Given this list of marker genes WDR36, NUP107-DT, CUL3, RNU6-1309P, RAVER2, ISL2, RUNX1, KHNYN, AP1S3, WEE2-AS1, TBC1D22A-DT, TMEM167B, CCDC77, UCHL5, HBP1, TRAF3IP3, GPX3, TIAM1, SMARCD2, HPRT1, ABCC8, ZNF354B, MTCO3P12, IFTAP, LINC00265, HNRNPMP2, MTA3, NDUFAF1, ADAT2, GTF2F1, INTS9, PAFAH2, SNAP47, NAGPA, OR13Z2P, SNRNP200, C18orf21P1, RBM14-RBM4, BCDIN3D-AS1, TIPARP, SOCS3-DT, RAD54L, FOXA1, SYT4, GIT2, AURKB, RBBP7, B4GAT1-DT, CRIPTOP5, RPS4XP20, TAF12-DT, CENPX, TBC1D22A, HERC4, TBCCD1, NEMF, PNP, SCAF11, GNAL, CBLN3, RHOBTB2, SMG9, SREK1IP1, OCIAD1, MT-TS2, RAPGEF2, HLA-DOA, MAP6D1, GAPDHP67, SLCO2A1, MT-TN (NCBI Gene Id 4570), LTN1, CISTR, AFG2A, HHAT, RPL27, LINC01345, IL1RAP, ZNF582, HNRNPH1, SMG7, TIAL1, CTNNA3, KLHL3, ANKUB1, ZNF567, ASAH1-AS1, MTFMT, OTUD6A, DAGLB, UCP2, SPEN, ZMYM4 (zinc finger MYM-type containing 4), DDIT4, PSMA2, ZNF181, EXOSC2, SNX14, RAD17, RNU6-380P, SDHAP4, KCNK1, CAPZA1, MSANTD4, INTS14, ACOT9, KDM5A, SNORA50C, RN7SKP6, ZNF318, TUBA1B-AS1, RN7SL567P, ENTPD1-AS1, SCAMP2, KRT42P, MALSU1, RNU6-619P, WDR19, RNU6-1077P, NUF2, PSMD3, WDR11-DT, RRAS2, GSTA11P, MT-TA, RPL37 (ribosomal protein L37), RPL30P6, SQSTM1, PLEKHG2, MPLKIP, CBR3-AS1, EFCAB14, IRS4, JMJD4, NOL6, SEMA5B, PIGM, SCMH1, ALDH7A1, GATB, ENSG00000223343, APONP (apolipoprotein N, pseudogene), LINC02901, TRIM44, PFKM, SNHG25, LINC02541, LINC00668, BEND6, IFT46, ACE, CAMK2D, PAN2, EPS15-AS1, TASOR2, IRS4-AS1, TRAPPC3, IPO4, SNHG30, BCL11B, MRPS31P5, MYL6B-AS1, LSG1, CERCAM, GLDC, TTC1, MMUT, MIR5695, DNAAF1, YIPF4, TMEM101, LAS1L, UTP3, DNAJB11, RBAKDN (RBAK downstream neighbor), SESN1, CACNA2D3, STAT3, KHSRP, PTMS, SPIDR, SLC25A37, SIPA1, NOLC1, PLCXD1, PCDHGA8, CREB5, STAT1, PMS1, SNU13, ZNF282, B4GALT6, PLEKHA2, TRIP4, LINC00662 (long intergenic non-protein coding RNA 662), HSPA8P16, MTERF1, BRD2, MCF2, SFXN1, ZNF212 (zinc finger protein 212), USP47, KIFC3, TACO1, RNU4-15P, MYLK3, LAMA4, KDM3B, APOA1-AS, AP4S1, ENSG00000257002, SPATS2, PPP1R11, ZSCAN16-AS1, PKMYT1AR, H2BC13, ZNF442, OAT, RPS8P5, TNFRSF10B, ABCA3, KMT2D, BSDC1, BCL6B, ATP2B4, H2BC21, TNRC6A, ERVMER34-1, EPCIP-AS1, COL1A2, LENG8-AS1, CERS6, SYDE2, H2BC4, LINC00939, ZNF117, CCDC163, MT-TC, DNPEP, LINC02846, FSTL1, ZNF239 (zinc finger protein 239), BDNF, SERINC1, EFCAB7, ZNF609, UBE2B, SNORD14E, CTTNBP2NL, SLMAP, TMEM41A, VBP1, LYPLA2, KLF15, NHSL2, MIATNB, NDUFS6P1, LRRC49, ZNF582-DT, AK3P2, ALG10 (NCBI Gene Id 84920), MT-ND4, SLC35A3, ZNF274, TUBGCP3, RNU6-847P, SLC9A1, ZNF736, MIR570, GTSE1, KATNB1 (NCBI Gene Id 10300), ASAH1, VDAC3, ARK2N, MADD, ELAVL2, LRRC45, CARMIL1, AK6, MST1P2, RND1, ZNFX1, AQR, APPBP2, REPS1, ARL6IP5, FTH1P12, MFSD6, YAP1, STX18 (NCBI Gene Id 53407), RNA5SP273, ENSG00000227189, HSDL1, SNUPN (NCBI Gene Id 10073), THAP10, SPATA1, CDK5RAP1 (CDK5 regulatory subunit associated protein 1), CCDC65, PSME1, H2BC1, ANTKMT, KRT18P12, SNORD12C, ZNF337-AS1, ERV3-1, ENSG00000232995, RO60, MAN2A1, TLCD1, ZNF569, ST8SIA2, RNU6-307P, RNU6-432P, DONSON, KLHL7, NME9, PKD1L2, PNRC1-DT, DYNLT5, TSPEAR-AS1, ABR, CD160 (CD160 molecule), MAN2C1, MRPS30-DT, ZNF461, KCNS3, DCAF8, VAV3, MTND5P11, C17orf75, FAM114A2, GOLM2, BIRC7, GPRC5A, SDCCAG8, IGHV3-6, MIR1302-3, ZNF570, HUWE1, COX6A1P6, STARD10, MTO1, AGMAT, CYP1B1-AS1, SDC4, SNORD104, TMEM242, APPBP2-DT, ZNF793, RBM14, A1BG, VPS51, JMJD7, RGS5, PCYT2, LINC02488, ENKD1, GPATCH3, ADAR, CCDC149, SGK1, SLC16A12, NUB1, GBA1, ARHGAP32, FBXW7, NUTM2A-AS1, COX16, TBC1D9B, LARP4, SF1 (splicing factor 1), MRPL39, MYO1C, FIRRE, SSTR5, LINC01596, PHF23, RRN3P1, ZNF684, KMT5C, TULP3, MPHOSPH8, SPTBN4, SCFD1, MTPN, TBX18, GLI3, SFRP2, ZNF772, LINC02043, ABCB10, CYP2A6, PLAAT5, ALG10B, ATP5PBP7, ARAP3, ADPRHL1, SORT1, RABGEF1P2, SSX2IP, TPD52, HMBOX1, MC1R, OGG1, MED6, CCDC183-AS1, TRIM38, P3H4, GPX1P1, BBLN, STK3, CENPL, PLCE1, LRP10 (NCBI Gene Id 26020), CACNA2D1, RPL30P15, GRM3-AS1, MRPS30, MT-TL2, BAD, SCAMP3, POLR1HASP, RAD51, AP3S2, GLI1, BCL9, ABCA17P, PPM1J, CROCCP2, HK2P1, ENSG00000215156, THG1L, SUGCT, TP53, RNF149, RUNDC3B, C1orf159, KLHL20, STX18-AS1, ZNF263, ZNF833P, UPF2, POU2F2, ATP6V0A1, ERMP1, SKAP2, MIR557, DNA2, ABTB3, MXI1, TNN, LAMTOR4, HOXC13-AS, B4GAT1, ENSG00000259737, TTC4, HAPLN2, TIPIN, CWC27, PRKG1, ZNF879, MIR5696, OR13Z3P, NLGN1 (neuroligin 1), RALGDS, TFE3, ADAP2, HARS2, GPR137, ECI1, PLD1, FAM66B, PLXDC1, NBN, FUNDC1, LINC01036, BACH1, PHF12, ANAPC5, ABLIM1, PDZD8, EIF4A3, TNS2, HNRNPL, ARF1, MEGF10, HARS1, PSORS1C1, RABGAP1L, KDM4A (NCBI Gene Id 9682), TRIM25, LINC00895, P4HTM, TRIM15, CTNNA1 (catenin alpha 1), BEST3, MUC1, CLTC, H2BC26, GPR19, ZNF638, PCGF3, RNU6-387P, ORMDL1, CPM, ABCA8, KIF2A, KLHL7-DT, IPP (NCBI Gene Id 3652), TRIM11, RPL26L1, ZNF573, DEFB109F, TXNIP, CBX1, DDX54, MVK, SCGN, HMGN4, KAT8, MMACHC, SMG8, CELSR3, GTSE1-DT, FHIP1A-DT, NR2E3, COA6-AS1, SLC27A6, LINC02851, FRMD7, FES, AHI1-DT, PLOD3, ENPP3, LINC02987, BMF, FAM230G, ITM2BP1, ACER3-AS1, FTCD, ZNF875, EXD3, ZFAS1, SBF2, TEFM, LFNG, MT-TH, ANKRD36, CWC25, EGFLAM, THUMPD3-AS1, MT-ND4L, TMBIM6, TASP1, NSRP1, COA6, ENSG00000277301, GULP1, UGP2, SSTR5-AS1, ZMYND8, MAN2A1-DT, DST, CHMP1B2P, RGMB, MGAT4A, CC2D2B, RHOBTB3, H4C16, IQCH-AS1 (IQCH antisense RNA 1, NCBI Gene Id 100506686), PLEKHM3, ARL14EP (NCBI Gene Id 120534), NUDT6, ZSCAN5A-AS1, SNF8, HINT3, DMAP1, INKA2, ATP11C, LRRC37A6P, BEX3, NSA2, GFM2, GLIS3, PAXBP1, NEU1, TCEAL1, PIPOX, HMGN1P37, MT-ND5, HEXIM2-AS1, SIPA1L3, SNORD65C, AURKAIP1, LINC02585 (NCBI Gene Id 102724368), TMEM181, MFAP3, RPL26L1-AS1, LY6K, PIK3R4, PABIR3, SOD1, GSTCD, DDX50, TELO2, CCT5P1, CASTOR3P, NKAPP1, RNU4ATAC11P, VKORC1, WDR87 (WD repeat domain 87), A1BG-AS1, PFDN1, LAMA4-AS1 (NCBI Gene Id 101927640), ANGPTL6, MIR7-3HG, MIR762HG, LINC00863, CCDC74A, LIPA (NCBI Gene Id 3988), FNIP2, NDUFB8P1, SCN3B, EXOSC3, ARID5B, PHACTR3, ZNF704, MED23, BLVRB, ALDOA, PLCB4, NCKAP5L, MED21, DOHH, HEXIM2 (HEXIM P-TEFb complex subunit 2), GABPB2, NOXA1, LINC01562, MORF4L2, TDP1, PEX3, TOR1AIP1, DAP-DT, ZFHX2 (NCBI Gene Id 85446), RPS25P9, TM2D1, ZNF428, OR5D2P, FCHO2, UXT, GFOD1, USP30, NCKAP1L, HEBP2, RCAN1, ANKRD40, TAF1, COL4A5, DSTYK, DHX16, TLX1 (NCBI Gene Id 3195), LTBP4, ENSG00000221083, SMAD4 (NCBI Gene Id 4089), SAMD9, TMEM63C, FYN, TSLP, DCTN6, RAB21, LGALS1, LRFN3, FKBP10, CLIP1, SLC22A11 (NCBI Gene Id 55867), TMEM184C, UACA, GLUD1P2, SIKE1, LINC02366, PPP1R3D, MYL6, WNT8A, MIR4519, PLA2G4A, CROCCP3, PPP1R14C, CEP170, NME1, SNRNP27, AVIL, AARS2, BAZ1A-AS1, SOD1-DT, SLFN12, DBF4B, DCTN6-DT (NCBI Gene Id 118597835), MIR1915, GTPBP2, MYPN, BOLA1, LRRC27, DENND2C, TAF9, ENSG00000260288, PNRC1, SPOPL, JAKMIP2-AS1, ZNF829, RPL32P27, RNU7-143P, HELZ, FAM3C, CENPK, H2BC12, ERC2, MUC20-OT1, LINC01775, CEPT1, OR1X5P, LETM2, ZNF445, ZNHIT1 (NCBI Gene Id 10467), RERE, FBXO46, DCLRE1C, EPHX4, MCF2L2P1, GRB2, ANKRD26P4, RMDN3, RNF122, MINDY3, REXO4, LYSMD4, ST7L, MYO15A, MT-TY, PGK1, GNG4, SLC25A12, MYCBP2 (MYC binding protein 2), HSD17B11 (NCBI Gene Id 51170), ITGB3BP, DRAM2, LIPG, YWHAZ, WDR11, PCLAF, CD247, PFN2, CDRT8, DEK, ZNF227 (zinc finger protein 227), OCEL1, LENG8 (NCBI Gene Id 79162), CWF19L1, RACGAP1, GFOD1-AS1, TPMT, DUSP7, DNAJB6, MIR3143, MPP7, LEKR1, PDXK, ATP5MC3, TMEM177, TMEM242-DT, BCLAF3, TUBA1B, C5orf34, ABCA9, TICRR, RASSF4, GUSBP18, CTNNA1P1, FRA10AC1, CCT8, ZNF530, MTR, AHI1, TENT5D, TMED2, INTS12, RNF207, MLX, CDC42SE1, JPX, EWSAT1, XCR1, BTG3-AS1, RAI14, ARHGAP30, MANCR, TMEM38B, GHR, BBS1, FAM151B, ENSG00000244137, TP53BP1, PPM1K, MIR4505, RPL36, ZC3HC1, FAM151B-DT, IL23A, SH2D6, VMP1, CS, MT-TR, FNDC3A, FABP5P3, TPT1P10, TBC1D14, RPS20P21, SEC24A, ZSCAN5A, LIMA1, SYCE2, ALG6, RFTN1, RNU4-2, NME1-NME2, LINC02567, FRS3, SAMD4B, EPB41L2, THAP4, CENPJ, SPSB1, BBS9, CSDE1, TNFSF11, IER2, GDF5, SPEG, SNORA71, EMSY, SLC24A1, TOP3B, FRMD4A, ARRDC3, ZNF221, GPC5-AS1, POP4, HMGN1P4, MYOM2, MAPT, NAT1, KRT19P2, TTC3, SMG7-AS1, UTP14C, NUP107, RNU6-788P, MTF2, UNC80, PITPNM3, CELSR1, FAAHP1, NFATC4, CHD3, RND2, CENPQ, PWWP3A, ADA, THOC5, TNR, KRT36, ANKFY1, BRAT1, ZNF780B (NCBI Gene Id 163131), BNIP3L, ZNF131, SPATA17-AS1, FHIP1A, DPY19L4, MORF4L2-AS1, ITGB4, GRAMD2B, FBXO28, EMC3, ACSF3, PLEKHH2, TMEM109, QSER1, OR2U1P, SSBP1, here is a description of the gene set: from publication Yevshin I, Sharipov R, Kolmykov S, Kondrakhin Y, Kolpakov F (PMID 30445619) studied in species Homo sapiens Human Gene Set: ZNF680_TARGET_GENES Genes containing one or more binding sites for (ZNF680) in their promoter regions (TSS -1000,+100 bp) as identified by GTRD version 20.06 ChIP-seq harmonization.